Given this list of marker genes AMPD2, FOXJ1 (forkhead box J1), NPHS1, ADIPOQ, PODXL, NPHS2, LAMB2, JAG1, NOTCH2, ASXL1, IQGAP1, MYO1E, MAGI2, here is a description of the gene set: The process whose specific outcome is the progression of a glomerular epithelial cell over time, from its formation to the mature structure. Glomerular epithelial cells are specialized epithelial cells that form part of the glomerulus; there are two types, glomerular parietal epithelial cells and glomerular visceral epithelial cells. studied in species Homo sapiens Human Gene Set: GOBP_GLOMERULAR_EPITHELIAL_CELL_DEVELOPMENT